The following is a description of a gene set: studied in species Homo sapiens Binds to and increases the activity of a receptor signaling protein tyrosine kinase. Human Gene Set: GOMF_RECEPTOR_SIGNALING_PROTEIN_TYROSINE_KINASE_ACTIVATOR_ACTIVITY, and this is the list of marker genes: CCL5, ALK, ALKAL2, LTK, ALKAL1